Given this list of marker genes ATPSCKMT, VCPKMT, SETD2, EEF2KMT, CSKMT, SETD3, ANTKMT, here is a description of the gene set: Human Gene Set: GOBP_PEPTIDYL_LYSINE_TRIMETHYLATION The methylation of peptidyl-lysine to form peptidyl-N6,N6,N6-trimethyl-L-lysine. studied in species Homo sapiens